Given this list of marker genes Rora, Atf4, Tnf, Hc, Ndrg2, Cxcl17, Ccl2, Nox1, Flt1, Gata4, Il1a, Bsg, Nutf2, Brca1, Il6ra, Flt4, Adamts3, Arnt, Adora2b, Cyp1b1, Sulf2, C5ar1, Nutf2-ps1, Nodal, Hpse, C3, Ccr2, Ccbe1, Sars1, Il1b, Sulf1, Stat3, C3ar1, Rela, Eif2ak3, Aqp4, Il6, Adgrg1, Isl1, Hif1a, Ptgs2, here is a description of the gene set: The appearance of vascular endothelial growth factor production due to biosynthesis or secretion following a cellular stimulus, resulting in an increase in its intracellular or extracellular levels. Mouse Gene Set: GOBP_VASCULAR_ENDOTHELIAL_GROWTH_FACTOR_PRODUCTION species: Mus musculus